Given this list of marker genes SLC5A1, here is a description of the gene set: species: Homo sapiens part of: SLC transporter disorders Reactome Pathway: Defective SLC5A1 causes congenital glucose/galactose malabsorption (GGM) Sodium/glucose cotransporter 1 (SLC5A1 aka SGLT1) actively and reversibly transports glucose (Glc) into cells by Na+ cotransport with a Na+ to glucose coupling ratio of 2:1. SLC5A1 is mainly expressed in the microvilli of intestine and kidney and responsible for the absorption of sugars. Overexpressed SLC5A1 has been found in various cancers, possibly playing a role in preventing autophagic cell death by maintaining intracellular glucose levels. Defects in SLC5A1 can cause congenital glucose/galactose malabsorption (GGM; MIM:606824), an autosomal recessive disorder manifesting itself in newborns characterised by severe, life-threatening diarrhea which is usually fatal unless glucose and galactose are removed from the diet.